The following is a description of a gene set: Electron transfer in Complex I. Pathway ID: N00995. Pathway type: Reference. Pathway class: nt06460 Alzheimer disease. Human Gene Set: KEGG_MEDICUS_REFERENCE_ELECTRON_TRANSFER_IN_COMPLEX_I species: Homo sapiens Pathway Definition from KEGG: NADH -- CxI -> Q, and this is the list of marker genes: NDUFAB1, NDUFB1, NDUFA5, NDUFV3, NDUFB10, NDUFS7, NDUFS5, NDUFB9, NDUFB2, NDUFS6, NDUFA8 (NADH:ubiquinone oxidoreductase subunit A8), NDUFB7, NDUFA6, MT-ND4, NDUFA11, NDUFB6, NDUFC1, NDUFA1, NDUFA4, NDUFS1, NDUFS2, NDUFA3, NDUFS3 (NCBI Gene Id 4722), NDUFB3, MT-ND3, NDUFV1, NDUFB5, NDUFA13, MT-ND5, NDUFA9, MT-ND6, NDUFA10, MT-ND2, NDUFB11, NDUFV2 (NADH:ubiquinone oxidoreductase core subunit V2), NDUFC2, NDUFS8, NDUFA7, NDUFS4, NDUFB8, NDUFA2, MT-ND1, NDUFB4, NDUFA12